Given this list of marker genes SPOCD1, PIWIL2, TDRD9, DDX4, PIWIL1 (NCBI Gene Id 9271), here is a description of the gene set: studied in species Homo sapiens Human Gene Set: GOBP_TRANSPOSABLE_ELEMENT_SILENCING_BY_PIRNA_MEDIATED_HETEROCHROMATIN_FORMATION A transposable element silencing mechanism in which a Piwi-associated RNA (piRNA) triggers heterochromatin assembly. Heterochromatin is a chromatin conformation that is refractory to transcription.